Given this list of marker genes Vps52, Fzd7, Ets2, Elf5, Pou5f1, Erf, here is a description of the gene set: The process in which relatively unspecialized cells acquire specialized structural and/or functional features of an ectodermal cell. Differentiation includes the processes involved in commitment of a cell to a specific fate. species: Mus musculus Mouse Gene Set: GOBP_ECTODERMAL_CELL_DIFFERENTIATION